Given this list of marker genes ATP6V1H (NCBI Gene Id 51606), AP2S1, AP2A2, AP2B1, nef, AP2M1, ARF1 (NCBI Gene Id 375), AP2A1, LCK, CD4, here is a description of the gene set: The presence of Nef accelerates endocytosis and lysosomal degradation of the transmembrane glycoprotein CD4. CD4 has its own internalization motif, though this motif is normally concealed by CD4 interaction with Lck, a tyrosine kinase. Nef is known to disrupt this interaction and then facilitate a cascade of protein interactions that ultimately result in the degradation of internalized CD4 protein. The final set of protein interactions that direct Nef to the beta-subunit of the COPI coatomers are at this time unclear.<br><br>A benefit for the virus from CD4 down-modulation is abolition of interaction between the receptor and the Env protein of the budding virus, which likely increases HIV release from infected cell as well as infectivity of viral particles. part of: Nef-mediates down modulation of cell surface receptors by recruiting them to clathrin adapters Reactome Pathway: Nef Mediated CD4 Down-regulation species: Homo sapiens